Given this list of marker genes CTDNEP1, PDGFA, MIR132, SAMD8, SIRT1, NR3C1, NR5A1, LPIN1, FBXW7, PLA2G6, MIR96, PLAA, TMX1, ZBTB20, RPTOR, ABCG4, EIF6, CAPN2, NR0B1, LHCGR, PRKAA1, LPCAT3, KAT5, ABCG1, MIR33A (microRNA 33a), MBTPS1, GPER1, ASAH1, MIR185, SLC45A3, ABCD2, MIR1-1, AVPR1A, APOE, OGT, PLIN5, LEP, FGF1, CLCN2, CES1, CCN1, ENPP7, THRSP, SNAI1, NR1H2, QKI, ORMDL2, SPHK1, WNT4, SNAI2, INSIG1, CREB1, DCAF5, TNF, C7orf50 (NCBI Gene Id 84310), ABCA3, HTR2C, AVIL, FABP3, DDX20, ERLIN1, APOC1, SIRT2, ZNF750 (NCBI Gene Id 79755), PIBF1, SCP2, HSD17B13, SLC27A1, STARD4, IDH1, TSPO, FGFR4, TREX1, XBP1, PAQR3, ACADL, WDTC1, CNEP1R1, DKK3, PRKCD, INS, KAT2B, ARMC5, APOB, PAQR4, EGR1, LPCAT1, SIRT3, PDK4, ASXL3, CD74, GGCX, PCK1, PTGS2, SPHK2, AKT1, MIR766, SCARB1, CREBL2, IGFBP7, SREBF1, ACADVL, RAB38, SERPINA12, PRKG1, C3, PDGFB, GFI1, GPIHBP1, BMP6, KPNB1, MLXIPL (NCBI Gene Id 51085), AQP8, PLA2G3, NR1H4, BMP5, MIR204, CEACAM1, H6PD, NR5A2 (nuclear receptor subfamily 5 group A member 2), ABHD6, NFKB1, SCAP, AKR1C3, GPLD1, MBTPS2, FABP5, CYP7A1, MIR182, CHP1, MALRD1, MIR30C1, DHH, ORMDL1, MTOR, ABCD1, IL1B, UBR4, APOA4, MID1IP1, MIR342, BMP2, MIR9-1, MAPK1, MFSD2A, POR, GIP, ADGRF5, SORBS1, BGLAP, SIRT4, CCDC3, KLHL25, APOA5, MIR206, GPR146, ADM, LDLR, PPARA, ATP1A1, MIR98, CGA, LPGAT1, DGAT2, PRKACA, PDE8B, PRMT3, SEC14L2, MIR548P, FSHB, NR1D1 (nuclear receptor subfamily 1 group D member 1), ACSL3 (NCBI Gene Id 55484), RDH10, PROX1, ELOVL5, ORMDL3, DKKL1, SREBF2, ANGPTL4, GPRC6A, BRCA1, TRIB3, APOC2, ERLIN2, APOC3, INSIG2, DGKQ, GNAI1, DAB2, NR1H3, HTR2A, FGF19, HTR2B, STAR, MLST8, MIR29B1, ABCA2, REST, SIK1, AVP, IFNG, here is a description of the gene set: Human Gene Set: GOBP_REGULATION_OF_LIPID_BIOSYNTHETIC_PROCESS Any process that modulates the frequency, rate or extent of the chemical reactions and pathways resulting in the formation of lipids. species: Homo sapiens